Given this list of marker genes Pfkp, Aldoart1, Pfkm, Pfkl, Aldoc, Aldob, Fbp2, Fbp1, Aldoart2, Aldoa, Ifng, here is a description of the gene set: The chemical reactions and pathways involving fructose 1,6-bisphosphate, also known as FBP. The D enantiomer is a metabolic intermediate in glycolysis and gluconeogenesis. studied in species Mus musculus Mouse Gene Set: GOBP_FRUCTOSE_1_6_BISPHOSPHATE_METABOLIC_PROCESS